Given this list of marker genes AGRN, VPS13C, VPS33B, USE1, WASHC1, RUBCNL, HLA-DRB3, TBC1D5, CEACAM6 (CEA cell adhesion molecule 6), SBF2, ACAN, DEFA1B, ARL8A, TLR8, PDE1C, LAMTOR3, MCOLN2, MMD, CYB561, IL4I1, CLEC16A, UBQLN1, AP1S2, VPS33A, ATP6V1G2, MFSD1, FCMR, IDS, ATP6V1D, ATP6V0A4, NAPRT, DSN1, DAB2, CTSC, ARRDC3, RAB7B, TBC1D14, HEXB, BST2 (bone marrow stromal cell antigen 2), PIGR, NEU1, DNASE2, ASAH1, MLST8, ATP6V1G3, RILP, HPS4, WIPI1, WDFY3, PCYOX1, ATP6V0B, SMPD1, SIDT2, OCA2, CALCOCO2, DYNC1H1, KLHL22, KCNE1, KICS2, CYLC1, STX7, PIP4K2C, GPC1, CBLIF, HLA-H (NCBI Gene Id 3136), NSG1, AP1S3, HCK, ATP6V1C2, UBXN6, B2M, CST7, NCOA4, ABCA3 (NCBI Gene Id 21), MAPKAP1, GLB1L, CTSS, VPS35, CHMP4A, CCZ1, HSPG2, GUSB (NCBI Gene Id 2990), FTL, PIK3R4, STING1 (stimulator of interferon response cGAMP interactor 1), ITFG2, CCT8, OCLN, SURF4, CCDC115, BACE1, KCMF1, DEPDC5, PSEN1, CPNE3, ZNRF1, LGMN, PIP4K2B, SLC3A1, WDR41, NBR1, BORCS5, BPI, PLD1, SLC39A14, LRP2, MIOS, FABP5, NPRL2, FNBP1, SULT1C2, OPTN, NEU4, RPTOR, CTSH, ATP6V0A2, GPC5 (glypican 5), DDOST, SIDT1, TMEM175, AP3B1, GC, SPG11, RMC1, SPPL2B, ATP8A1, SFTPB, MFSD12, CHMP2A, ENPP1, RNASEK, RAB39A, UBA1, ANK2, FPR1, RAB8A, TPCN1, UBQLN2, NAPSA, CYB561A3, ATG5, SNX2, PRF1, TMEM30A, GNB1, AUP1, GGA3, AP5M1, WDR48, CHMP3, VPS18, ATP6V0A1, RNASE3 (NCBI Gene Id 6037), VPS13B, SEH1L, OLFM4, GPC4, CDC42, VPS16, ARSB, MAGT1, NCSTN, LAMP5, SLC15A4, CAPN2, RUBCN, SLC36A1, HSPA8, CPNE1, SLC26A11, RAB12, RAB14, RNF167, CD164, MFSD8, RNF13, OGN, SLCO4C1, AP2A2, PIP4K2A, PADI2, LPCAT1, FAF2, CD1B, AP1M1, RAB27A, GAA, STX17, IFITM2, IRGQ, ABCB6, HLA-DQB1, UBQLN4, FASLG, HLA-DOA, TMEM63C, BORCS6, AP1G1, GABARAP, PLA2G15, ARSA, CALCRL, CAPN1, LAPTM5, ATG9A, BLOC1S1, IFNAR1, DOC2A, TMEM9B, SRGN, ATRAID, LAMTOR2, RAB7A, RAB9B, ABHD6, ATP6V1F, AHNAK, HLA-F, ANXA6, CD63, DTX3L, S100A7, SCARB1, STARD3, CD74, TMEM150C, OCIAD1, TSC1, CYB5R3 (cytochrome b5 reductase 3), SAR1B, LAMP1, SIAE, TSC2, MINAR2, IFI30, ABCA2, ACP2, FTH1, CHMP4B, SHKBP1, LNPEP, GABARAPL2, MAN2B2, STOM, WDR81, ATG14, HGS, TXNDC5, GLIPR1, RNASE6, AP3M1, ANPEP, ABCA5, PLD4, AP5S1 (adaptor related protein complex 5 subunit sigma 1), MYO6, CTSK, TMEM63B, RNF152, MYO7A, AP1B1, MANBA, ATP11C, ACP5, RRAGB, DAPK2, MLC1, CTBS, TUBB, BORCS8, TMEM74, ATP11B, RAMP3, SPAAR, PSMD1, SLC2A8 (solute carrier family 2 member 8), CLTC, VMP1, ARRB1, MPEG1, TMEM203, ARSG, SGSH, TRAPPC1, CDIP1, SLC30A4, PEG3, FNIP1, TMEM179B, ARSK, EVA1A, GPR137, OCIAD2, THBD, GABARAPL3, MARCHF3, CREG1, FNIP2, C3, HLA-DPB1, ENTPD4 (NCBI Gene Id 9583), GFAP, RAB3A, CLCN5, ATG16L1, HLA-DQA2, SNX16, NPC1, MYL11 (myosin light chain 11), PIP4P1 (phosphatidylinositol-4,5-bisphosphate 4-phosphatase 1), ATG13, LRP1, MAP1LC3B, AP1M2, STX4, ATP6AP2, CTSD, SLC15A3, ATP6V1B2, SDC2, NSF, GALNS, TMEM230, MARCHF9, PIK3C3, ARSD, ATG9B (autophagy related 9B), ATP6V0C, CTSZ, TMEM106B, LIPA, SPPL2C, HEBP2, AP3D1, VAMP8, AKR1B10, MAN2B1, SLC48A1, PDGFRB, SLC31A2, PPT2, GDAP2, VOPP1, SPAG9, CRYAB, TECPR1, LAMTOR5, HAS2, WDR83, HLA-DRB5, LUM, RAB29, SLC7A5, IST1, RAB5C, VPS26A, TTR, DCN, RAB44, CD1D, CXCR4, DRAM1 (DNA damage regulated autophagy modulator 1), SNX14, WDR59, GNAQ, APP, TOM1L1, EEF1A1, SRC, PTGES2, AP2M1, BECN1, RNASET2, RDH14, ADA2, AP5B1, PCSK9, CHMP7, CSPG4, RAB9A, FFAR4, NCAN, ATP6V1G1, ATXN3, EGF, IMPDH1, SPACA3, ATP6V1B1, SLC22A17, CPA2, SLC36A2, MAPK15, RAB37, HGSNAT, RAB24, CEACAM8, AGA, TRIM21, SLC29A3 (NCBI Gene Id 8072), DAGLB, MTMR2, GPC2, GNAI3, TM9SF1, SYT7, AZU1, ACTR10, RAB3GAP2, SLC44A2, RICTOR (NCBI Gene Id 253260), GLB1L3, SH3GLB1, NRBF2, PLBD2, UBE2A, CKAP4, RRAGC, ATP6V0D2, VAMP7, LITAFD, NAGLU, RAB10, ANXA2, TOLLIP, CSF3R, RAB30, GRIN2B, BCAN, AP2B1, GLB1, STX3, ACLY, SORT1, FUCA1, ACP4, TSPAN1, PYCARD, CTSV (cathepsin V), RAB2A, HLA-DRB4, SLC46A3, TEX264, HYAL2, FLCN, RUFY3, CLNK, TFE3, TM4SF5, ULK3, TMEM59, VAMP4, GZMB, ORM2, SDC1, PSAP, SLC66A1LP, NAAA, PLBD1, VCAN, HLA-DRB1, CHIT1, TNFAIP8L2 (NCBI Gene Id 79626), VAC14, TNFAIP3, GNS, VPS4A, KERA, RRAGA, CLEC10A, VPS41, GNB2, M6PR, NSG2, TBC1D7, ATP13A2, SERPINB3, MCOLN1, PLEKHM1, CFTR, ACR, ATP6V0D1, CHID1, PRSS2, CMTM6, GGH, ACP3 (acid phosphatase 3), ATP6V0E1, MITF, ZFYVE26, CTSB, ATP6V1A, CCZ1B, HPS6, PRCP, TUBB4B, MNDA, VLDLR (NCBI Gene Id 7436), OSTM1, VAPA, WDR45B, CTSF, SDCBP, TMEM150B, VAMP1, CD1C, NAGA, SPNS1 (NCBI Gene Id 83985), CHMP6, LRRK2, BGN (biglycan), PRKCD, GABARAPL1, KCNE2, LRBA, TINAGL1, NAPG, SLCO2A1, CPPED1, TINAG, PLA2G10 (phospholipase A2 group X), FRK, PRSS16, WDR24, SLC17A9, BLOC1S2, VMA21, TMEM163 (NCBI Gene Id 81615), MST1R, LDLR, TRAF3IP3, VTI1B, DNAJC13, FYCO1, PLA2G5, DEFA4, NCF1, TPP1, SPACA7, NEU2, HLA-DQB2, WIPI2, CTSA, PIP4P2, ELAPOR1, PYGB, GNLY, LRRC8E, SNX6, VPS39, PRTN3, TAB2, TMEM199, AP2A1, NPC2, SLC36A4, TRIM17, BRI3, MEFV, ARHGAP45, SLC17A5, FUT10, LRRC8A, CHMP4BP1, AMBRA1, CHMP1B (NCBI Gene Id 57132), USP6, TRIP10, SLC3A2, PLAAT1, MAPK1, SQSTM1, KXD1, ACE, GRN, C3AR1, VCP, TICAM1, SLC30A2, CLCN7, TMEM25, RB1CC1, TM4SF19, ABCC11, IRAG2, PA2G4, LYN, GNA11, SLC2A13, ATG16L2, FLOT1, LYZ, SVIP, PRDX6, ZC3HAV1, RAB38, ANKFY1, RNF183, PI4K2A, GLA, TMEM192, ZNRF2, NHLRC3, HYAL3, MYO5A, CHMP1A, SLC12A4 (solute carrier family 12 member 4), TFEB, NCF4, DEFA3, P2RX4, SNAP23, SLC66A1, UVRAG, SFTPD, SNCA, ZFYVE1, B4GALT1, PSAPL1, CD68, TLR9, LARS1, WDR11, GALC, GZMH (granzyme H), GCA, CTSW, TMEM97, GOPC, IFITM1, RETN, SPPL2A, PRKD1, RHEB, NEU3, RRAGD, HLA-DMA, CD1E, TLR7, DBNDD2 (dysbindin domain containing 2), TMEM45B, TBC1D17, KIF5B, MCOLN3, STXBP2 (syntaxin binding protein 2), PLEKHF1, APOB, JMY, DPP7, UBA52, EPDR1, TRIM29, LAPTM4A, SLC2A6, ELANE, HLA-DQA1, CYBRD1, SLC35F6, SERPINB13, HEXA, GPR143, SLC37A3, ATG4B, GPR137B, SNAP29, LITAF, PLD3 (phospholipase D family member 3), MAP1LC3A, ATP11A, SLC12A9, MREG, NDUFC2, CALR, WWOX, TYR, LAMP3, TCN2, VNN1, HLA-DOB, CP, C9orf72, CRHBP, ATP6V0E2, SEC13 (SEC13 homolog, nuclear pore and COPII coat complex component), TLR3, HLA-DMB, CHMP4C, INSR, GPR155, SLC11A2, KLC2, ENPEP, SDC3, CPQ, NKG7, ULK2, HRNR, NPRL3, CLTA, TCIRG1, TPCN2, GLB1L2, VAT1, RNF19B (NCBI Gene Id 127544), WASH3P, VTI1A, ABCC10, CTSG, BCL10, HPSE, RFFL, KPTN, VASN, DNASE2B, TRIM32, HSP90AA1, TOM1, PGAP6, SZT2 (SZT2 subunit of KICSTOR complex), IDUA, CTSO, ADRB2, BBC3, TRPM2, PLA2G4E, UNC93B1, PRMT1, GYG1, KCNK6, STS, RNASE2, GBA1, CLCN4, ATP6V1E1, TRIM23, GNAI1, ARL8B, SLC30A3, AP5Z1, SAR1A, PPT1, MTOR, ATP10B, HAP1, MPO, ANXA11, TP53INP2, ACTR2 (NCBI Gene Id 10097), SYNGR1 (NCBI Gene Id 9145), CHMP2B, ATP6V1C1, ABCD1, VPS36, CTNS, MARCHF2, HTT, SLC49A4, KCNQ1, ITM2C, SLC7A14, LAPTM4B, TRPV3, MAP1LC3B2, IL1B, PRSS57, HPS1 (NCBI Gene Id 3257), TASL, IFITM3, SNX1, CXCR2, SLC11A1, STARD3NL, MGST1, RAB23, DNAJC5, SDC4, TMEM63A, LAMTOR4, PLAC8, GPC3, RAB3D, USP4, GPR137C, SCARB2, LAMP2, EPG5, GDI2, CHMP5, SLC38A7, TMEM9, CD34, ABCD4, CLCN6, ECE1, SRPX, COL6A1, NCF2, CLCN3, NFAM1, ANKRD27, SPHK2, TAX1BP1, TMEM138, PLAAT3, DEPTOR (NCBI Gene Id 64798), RPS6KC1, MARCHF1, GM2A, STK11IP, AP2S1, LMBRD1, MROH1, TMBIM1, CLN5, TMEM165, EEF1A2, HLA-DRA, RAB2B, ADAM8, TMEM79, TM6SF1, VPS11, ABCB9, GNPTG, MARCHF8, VPS13A (vacuolar protein sorting 13 homolog A), CSPG5, HLA-DPA1, TIAL1, ATP6V1H, ABCA13, LAMTOR1, DRAM2, CTSL, SESN2, GPC6, MEAK7, C6orf120, OSBPL7, TMEM208 (NCBI Gene Id 29100), SOD1, NPPA, SLC39A8, SERPINA3, ATG12, DLD, CSF3, DEFA1, SYT11, SLC36A3, DNAJC3, CAP1, YWHAB, ULK1, HYAL1, DPP4, SERPINB1, SLC38A9, ARG1, UNC13D, GLMP, ADA, IRGM, GRAMD1A, MAP1LC3C, GPLD1, PLEKHM2, AP1S1, FMOD, TBC1D25, RAP1B, OCRL, TP53INP1, FUCA2, USP5, CUBN, BORCS7, ANK3, GIMAP5, RAMP2, PRELP, SNAPIN, GNB4, OMD, CCT2, MFHAS1, CLN3, TBC1D12, ATP6AP1, RUFY4, here is a description of the gene set: A closed structure, found only in eukaryotic cells, that is completely surrounded by unit membrane and contains liquid material. Cells contain one or several vacuoles, that may have different functions from each other. Vacuoles have a diverse array of functions. They can act as a storage organelle for nutrients or waste products, as a degradative compartment, as a cost-effective way of increasing cell size, and as a homeostatic regulator controlling both turgor pressure and pH of the cytosol. Human Gene Set: GOCC_VACUOLE species: Homo sapiens